The following is a description of a gene set: LPA receptor mediated events from publication Schaefer CF, Anthony K, Krupa S, Buchoff J, Day M, Hannay T, Buetow KH (PMID 18832364) species: Homo sapiens Human Gene Set: PID_LYSOPHOSPHOLIPID_PATHWAY, and this is the list of marker genes: GNA14, LPAR4, ADCY2, FOS, ADCY1, RAC1, HBEGF, ADCY4, BCAR1, CXCL8, NFKBIA, GNAI2, JUN, GNA15, RHOA, ADCY8, GNAZ, GNG2, IL6, GNAI3, ADCY6, TRIP6, GSK3B, PIK3CB, GNAO1, ADCY9, PLCB3, GNB1, HRAS, GNAI1, MMP9, PIK3R1, PXN, AKT1, ADCY5, ADRA1B, PRKD1, TIAM1, CASP3 (caspase 3), LPAR1, CRK, ADCY7, PTK2, LPAR3, PRKCD, PTK2B, RELA, MMP2, GNAQ, NHERF2, SRC, PLD2, LPAR2, GNA13, MAPT, PLCG1, GAB1, GNA12, PRKCE, LYN, ADCY3, ARHGEF1, NFKB1, GNA11, EGFR